The following is a description of a gene set: Human Gene Set: GATA3_01 species: Homo sapiens Genes having at least one occurrence of the motif NNGATARNG in the regions spanning 4 kb centered on their transcription starting sites. This matches the GATA3 transcription factor binding site V$GATA3_01 (v7.4 TRANSFAC)., and this is the list of marker genes: AQP2, FZD1, LYL1, DMD, RBPMS, FAM221A, RAD9B (NCBI Gene Id 359947), MLEC, ERBB2, VGF, SHKBP1, IL13, CCL27, OSM, UBXN1, FZD4, IRX5, FIBP, NRGN, ANGPT1, IKZF2, PIAS1, HOXD10, ABL1, SYN1, OTOP2, VSNL1, TRIM10, TACC1, ATP2C1, CSMD3, KRT80, LINC02872, ISL1, NAA38, EDN1, MAML3, KRT72, ELF1, SLC25A13, MSN, CYP4B1, EPB42 (NCBI Gene Id 2038), SLC8A3, CACNA1F, HOXB6, SOX10, HOXA10, ZNF800, U2AF1L4, PRR18, CRLF1, ARHGAP30, HMBS, PNLIPRP2, ZNF385B, SYNCRIP, MITF, DMTN, RHD, B4GALT2, CDC42EP2, PFKFB1, IL5, KLF5, MSH5, PODN, SPRED2, AGPAT4, INTS3, SOX12, FERMT1, SH3GLB2, MYO18A, GDF7, ABCG8, SATB2, FILIP1, MYL7, FKBP2, RBM14, VPS29, PHOX2B, CREBL2, PRRX1, SLC30A1, NECTIN4 (NCBI Gene Id 91969), PSD4, BMP4, TBX5, TF, APOE, NECTIN2, CYB5D1, XPR1, RHOBTB3, SCUBE3, BNC2, ASIC2, SAT1, SH3KBP1, RGS12, HOXA2 (NCBI Gene Id 3199), BMP10, CLVS1, HSPG2, PI15, ANKS1B, POU2F1, NLGN3, ESR1, PSENEN, SSTR3, MYRF, GPR85 (G protein-coupled receptor 85), DAB1, MECP2, INHBB, FAM107B, SLC41A1, ZNF703, GUCA2A, PLEKHG6, PRR34, HOXC11, SPRY4, PPP1R12A, TRIM15, AMHR2, IL22, IGFLR1, AJUBA, ZFPM1, OSR1, APTX, HDAC9, NR5A2 (NCBI Gene Id 8768), PTGIR, JADE1, CTF1, BMP6, LONRF3, LMO3, PHF21B, KCNK3, ABCA12, GLG1, PPP1R21, MCTS1, FBXO11, SNCA, EPHB3, IER5L, DIO2, LRP1, NCDN, FER, EFEMP1, MFF, CREB5, UBR5, TRPM3, XPO6, DLX3, LINC01312 (long intergenic non-protein coding RNA 1312), IGF1, CNTF, MBNL1, SGIP1, IL17B, SLC4A1, HBZ, IL34, FES, BCL2L1, TP63, ILRUN, NR5A1, SORBS1, CD34, RABGAP1, RHCE, TMEM88, PILRB, ECHDC2, ARL4A, CNTN6, RBMX, PLA2G1B, FMO1, SLC44A1, INHA, MASP1, MAP4, LEAP2, ERG, CA7, ABCG5, SRRM1, OARD1, MEIS2, TTBK2, EN1, SLC36A2, RORA, CCDC85B, BIN1, TSPAN1, LINC00670, PMS2P5, NTF4, CMAS, EPX, TNXB, USH1G, SALL1, MYO19, IL1RL1, NEUROD6, TMEM196, ALKBH6 (alkB homolog 6), SLC26A9, STAG3L4, SUSD1, RTF1, FOSL2, LMO1, CAPN1, MED26, DCAF11, HNRNPL, FLI1, SOX5, DRD3, GRID2, SIX1, ERG28, RAB3C, HCRT, PENK, ELAVL4, FOXA1, LCOR, RBM39 (RNA binding motif protein 39), PDHA2